The following is a description of a gene set: from publication Naba A, Clauser KR, Mani DR, Carr SA, Hynes RO (PMID 28071719) Mouse Gene Set: NABA_MATRISOME_ANGIOGENIC_PANCREATIC_ISLETS In this study, we aimed to characterize changes in the extracellular matrix (ECM) composition during insulinoma progression using a quantitative proteomics approach. To do so, we chose a mouse model of insulinoma, a subtype of pancreatic neuroendocrine tumors, characterized by the expression of SV40 large T antigen (Tag) in pancreatic beta-cells driven by the rat insulin promoter (RIP) (RIP1-Tag2 model). This model follows a well-defined timeline of tumor progression: hyperplastic islets appear by 4 weeks of age, angiogenic islets by 7-9 weeks, solid tumors at 10 weeks, and large and invasive adenomas by 12-13 weeks. Using quantitative proteomics based on isobaric peptide labeling (iTRAQ), we profiled the ECM proteomes or matrisomes of various stages: normal pancreatic islets, hyperplastic islets, angiogenic pancreatic islets, and insulinomas. We focused on ECM and ECM-associated proteins along with proteins found in only one of the two replicates but with at least two unique peptides. Applying a moderated F-test, we identified proteins detected in statistically significantly different abundance in tumor samples (hyperplastic, angiogenic islets or isulinomas) as compared to normal pancreatic islets. The gene set lists the matrisome proteins detected in significantly higher abundance during the angiogenic stage of insulinoma progression as compared to normal islets and earlier hyperplastic stage of insulinoma progression. species: Mus musculus Matrisome proteins detected in significantly higher abundance during angiogenic stage of insulinoma progression compared to normal islets and relative to hyperplastic stage of insulinoma progression (RIP-Tag2 model)., and this is the list of marker genes: Postn, Efemp1, Kng1, Kng2, Fgg (NCBI Gene Id 99571), Fga, Fgb